Given this list of marker genes Eif4ebp1, Paf1, Pcid2, Anxa1, Rad23a, Kcnn4, Stat5a, Nr2e1, Pbx1 (NCBI Gene Id 98516), Usp2, Cul4a, Pafah1b1, Ska1, Atad5, Tas2r121, Apex1, Tfdp1, Ncapd3, Sgo2a, Camk2d, Cdc7, Adamts1, Cenpv, Pagr1a, Mta3, Crebbp, Eif4g3, Lef1, Phip, Nsmce2, Mark4, Csf1r, BC004004, Dync1h1, Pkp4, Cul4b, Mapre3, Fgfr2, Chmp3, Kat2b, Knl1, Cdc73, Vps4b, Klhl18, Poldip2, Map10, Chek2, Ereg, Nupr1, Med1, Ovol1, Drd3, Igf1r, Ncapd2, Rrm1, Cdk4, Pdgfb, Tas2r102, Gdpd5, Edn1, Anp32b, Egf, Anapc5, Kcna5, Kif20b (kinesin family member 20B), Ins2, Ube2c, Ino80 (INO80 complex subunit), Rab11a, Tert, Plrg1, Aurkb, Ccnb1-ps, E2f7, Numa1, Azin1, Usp19, Ube2e2, Mir744, Ccpg1, Map3k7, Gata4, Il10, Nusap1, Tgfb2, Cenpj, Fbxo5, Svil, Ccnb1, Foxg1, Rad21, Cenpe, Stra8, Rhno1, Prox1, Gipc1, Wnt10b, Tpr (NCBI Gene Id 74816), Ccdc57, Slf2, Smc4, Tgfa, Cdc6, Lsm11, Eif4g1, Orc1, Bub1, Ythdc2 (NCBI Gene Id 70219), Eif4e, Rbm46, Sh2b1, Birc5, Sphk1, Hyal1, Flt3l, Srpk2, Sin3a, Ubxn2b, Trp63, Poc1a, Ncaph, Lmnb1, Rptor, Mir124a-1, Shb, Ptpn11, Rgcc, Stxbp4, Igf2, Rrm2b, Ect2, Kif3b, Tbx2, Smc6, Akt1, Plcb1, Rad51b, Drd2, Msx2, Brd4, Rad51c, Sass6, Rad18, Mtbp, Smoc2 (NCBI Gene Id 80628), Ccnd1, Mepce, Xrcc3, Slf1 (SMC5-SMC6 complex localization factor 1), Ccne2, Trim21, Usp22, Adam17, Fen1, Anapc7, Pebp1, Dbf4, Racgap1 (Rac GTPase-activating protein 1), Ddr2, Smc2, Sfpq, Ascl1, Map3k20, Cul3, Hsf1, Phb2, Nr4a3, Pggt1b, Kif14, Cdc14a, Fgf10, Gpsm2, Incenp, Kmt2e, Plcg2, Abl1, Meioc, Stox1, Slc6a4, Dync1li1, Edn3, Lgmn, Mad2l1, Rab11fip3, Hes1, Psrc1, Rps6kb1, Rxfp3, Nsfl1c, Dazl, Cdc14b, Asns (NCBI Gene Id 27053), Npm1, Dmrt1, Tbx1 (NCBI Gene Id 21380), Cdc23, Cdc42, D1Pas1, Cdc20, Exoc7, Wnk1, Gli1, Rpl17, Wnt4, Larp7, Psmd10, Tunar, Ncapg2, Sstr5, Calr, Cit, Mad1l1 (MAD1 mitotic arrest deficient 1-like 1), Poc1b, Dynlt3, Mrgprb1, Igf1, Meiosin, Hoxa13, Cdc25b, Cd28, Ins1, Rad51ap1, Ankrd31, E2f8, Sox15, Ezh2, Ccn2, Cdc16, Pdgfrb, Cspp1 (centrosome and spindle pole associated protein 1), Mir124a-2, Ccny, App (amyloid beta precursor protein), Mir124a-3, Brca2, Becn1 (beclin 1, autophagy related, NCBI Gene Id 56208), Nanog, Camk2b, Tas1r2, Dusp3, Met, Cep295, Ccnd2, Cyp1a1, Spdya, Il1b, Cdc25c, Ttl, Cxcr5, Stat5b, Ube2b (ubiquitin-conjugating enzyme E2B), Trp53, Egfr, Tbx3, Ccne1, Trim32, Cdc25a, Rdx, Spag5, Ccdc15, Fntb, Anapc11, Neurog1, Fgfr1, Fosl1, Epgn, Pkp3, Cdca5, Ooep, Cpsf3, Rhoa, Gen1, Lfng, Fnta, Arf6, Mdm2, Stil, Tnf, Cdca8, Ndc80, Zpr1, Ddx11, Plk4, Wiz, Tal1, Hmgb1, Pkn2, Spast, Crnn, Aif1, Kif23, Ankrd17, Rock2, Cep120, Prdm9, Ncaph2, Piwil2, Bcl2l11, Cited2, Sirt2, Insr, Cdk1, Smpd3, Ppp1r35, Hnrnpu, Nkx3-1, Spdye4a, Tgm1, Ddx3x, Rps15a, Ppp1r10, Foxa1, Meis2 (Meis homeobox 2), Msx1, Gja1, Plscr1, Rrm2, Dyrk3, Lsm10, Chek1, Myc, Btc, Macroh2a1, Id2, Smc5, Fam83d, Mapk15, Ranbp1, Wnt5a, Tgfb1, Prkce, Prap1, Aurka, Tas2r124, Fgf8, Npm2, Ccnd3, Hspa2, Nup62, Lrp6, Rcc2 (regulator of chromosome condensation 2), Tmod3, Rara, Atrx, Tbx20, Mblac1, Il1a, Brca1, Tcf3, Mad2l1bp, Lrp5, Dtl, Bard1, Pim1, Ska3, Rb1, Smarcd3, Npr2, Nudt16, Prkca, Kat5, here is a description of the gene set: Mouse Gene Set: GOBP_POSITIVE_REGULATION_OF_CELL_CYCLE Any process that activates or increases the rate or extent of progression through the cell cycle. studied in species Mus musculus